The following is a description of a gene set: Human breast cancer has been characterized by extensive transcriptional heterogeneity, with dominant patterns reflected in the intrinsic subtypes. Mouse models of breast cancer also have heterogeneous transcriptomes and we noted that specific histological subtypes were associated with particular subsets. We hypothesized that unique sets of genes define each tumor histological type across mouse models of breast cancer. Using mouse models that contained both gene expression data and expert pathologist classification of tumor histology on a sample by sample basis, we predicted and validated gene expression signatures for Papillary, EMT, Microacinar and other histological subtypes. These signatures predict known histological events across murine breast cancer models and identify counterparts of mouse mammary tumor types in subtypes of human breast cancer. Importantly, the EMT, Adenomyoepithelial, and Solid signatures were predictive of clinical events in human breast cancer. In addition, a pan-cancer comparison revealed that the histological signatures were active in a variety of human cancers such as lung, oral, and esophageal squamous tumors. Finally, the differentiation status and transcriptional activity implicit within these signatures was identified. These data reveal that within tumor histology groups are unique gene expression profiles of differentiation and pathway activity that stretch well beyond the transgenic initiating events and that have clear applicability to human cancers. As a result, our work provides a predictive resource and insights into possible mechanisms that govern tumor heterogeneity. Mouse Gene Set: HOLLERN_EMT_BREAST_TUMOR_DN species: Mus musculus Genes that that have low expression in mammary tumors of epithelial-mesenchymal transition (EMT) histology. from publication Hollern DP, Swiatnicki MR, Andrechek ER (PMID 29346386), and this is the list of marker genes: Bspry, Dennd2d, Sdr42e1, Cldn4, Thrsp, Eps8l1, Ltf, Myo5b, Sptbn2, Fxyd3, Atp6v1c2, Ehf, Pof1b, Ceacam1, Rab25, Plekhg6, Shroom3, Ide, Grb7, Epb41l4b (NCBI Gene Id 54357), Epcam, Ildr1, Ripk4, Tmem79, Cldn1, Ap1m2, Spint1, Lrba, Dsg2, Arhgef16, Kif21a, Tmc4, Kcnk1, Elovl7, Klc3, Hip1r, Lsr, Tmem184a, Cdh3, Prss8, Apoc1, Sort1, Eps8l2, Efna3, Acot1, Tfap2c, Grhl2, Mal2, Gjb2, Marveld2, Zfp185, Crb3, Calml3, Kdf1, Celsr2, Tmem54, Il17re, Slc5a9, St14, Ckmt1, Wwc1, 2610528J11Rik, Ddr1 (discoidin domain receptor family, member 1), Fam83h, Cldn7, Esrp2, Tnk1, Blmh, Tmprss2, Chdh, Ocln, Cd24a, Rhpn2, Elmo3, Dsp, Cysrt1 (cysteine rich tail 1), Tmprss13, Dsc2, Evpl, Ptprf, Cldn3, Erbb3, Ppfibp2, Grhl1, Stard10, Clic3, Patj (NCBI Gene Id 435795), Dedd2 (death effector domain-containing DNA binding protein 2), Jup, Tmem30b, Wfdc18, Bnipl, Cblc, Epha1, Nipal2, Gm16136, Llgl2, Eppk1, Irf6, Ovol1, Krt15, Gsdma, Fzd6, Tjp3, Rnf43, Pkp3, Spint2, Nrtn, Nectin4, Cdh1, Bcl11a, Esrp1, Epb41l5, Ppif, Cxadr, Mpzl2, Endou, Stap2, Elf5, Map7, Cdcp1, Ccdc120, Myh14, Plekhh1